Given this list of marker genes ELOVL2, HACD2, TECRL, ELOVL6, ELOVL7, HACD4, ELOVL3, ELOVL5, HACD3, ELOVL4, TECR, HACD1, ELOVL1, here is a description of the gene set: The chemical reactions and pathways resulting in the formation of a very long-chain fatty acid. A very long-chain fatty acid has an aliphatic tail containing more than 22 carbons. species: Homo sapiens Human Gene Set: GOBP_VERY_LONG_CHAIN_FATTY_ACID_BIOSYNTHETIC_PROCESS